Given this list of marker genes NR5A2, GATA3, BMP6, SLCO1C1, DAB2, POR, EGR1, WNT4, PAX8, HIF1A, HPN, ARNT, ADM, RDH10, here is a description of the gene set: studied in species Homo sapiens Any process that activates or increases the frequency, rate or extent of the chemical reactions and pathways involving any hormone. Human Gene Set: GOBP_POSITIVE_REGULATION_OF_HORMONE_METABOLIC_PROCESS